Given this list of marker genes SFRP2, VANGL2, WNT11, SFRP1, TRIM28, WNT5A, here is a description of the gene set: The morphogenetic process in which an epithelium narrows along one axis and lengthens in a perpendicular axis contributing to the lengthening of the axis of an organism. Human Gene Set: GOBP_CONVERGENT_EXTENSION_INVOLVED_IN_AXIS_ELONGATION studied in species Homo sapiens